The following is a description of a gene set: PKA-mediated phosphorylation of CREB species: Mus musculus Mouse Gene Set: REACTOME_PKA_MEDIATED_PHOSPHORYLATION_OF_CREB, and this is the list of marker genes: Adcy1, Calm3, Prkaca, Adcy9, Prkar1a, Adcy2, Adcy4, Prkacb, Calm1, Adcy7, Prkar1b, Adcy3, Adcy8, Calm2, Adcy6, Adcy5